The following is a description of a gene set: species: Mus musculus Genes predicted to be targets of miRBase v22 microRNA mmu_miR_8095 in miRDB v6.0 with MirTarget v4 prediction scores > 80 (high confidence targets). Mouse Gene Set: MIR_8095 from publication Chen Y, Wang X (PMID 31504780), and this is the list of marker genes: Far1, Slc5a1, Rnls, Kpna1, Pcdh15, Gart, Tnfsf13b, Mageb4, Sco1, Lcorl, Ms4a18, Golm1, Ptgdr, Miga1, Gm15091, Gm10439, Gm15107, E2f8, Cops2 (NCBI Gene Id 98909), Derl2, Slitrk4, Scfd1, Chd6, Sgo1, Fgf14, Stk33, Prkg2, Luc7l2, Tmem161b, Gpr33 (G protein-coupled receptor 33), Sgtb, Fbxo33, Spdye4a, Arid4b (NCBI Gene Id 94246), Hcrtr2, Nap1l3, Amfr, Pla2g2c, Rps6ka2, Tpgs2, Col26a1, Tkt, Pithd1 (NCBI Gene Id 99969), Usp50, Arfip1, Gm15097, Klhl31, Tmx4, Tecpr2, Gm15093, Mroh9, Adamtsl3, Ott, Smarca5, Luzp4, Acbd5, Gmps, Mapk1, Map4k5, Zfp111, Thap1, Gm15114, Hadh, Smg1 (NCBI Gene Id 72492), Cntn3, Rab39b, Klhl4, Vsig1, Gm15127, Zfp654, Ctdspl2, Fut4, Mylk, Rbm17, Cfap36, Leprotl1, Nap1l1, Arhgap12, Zcchc3, Spata6l, Pum2, Gria4, Gm15080, Scg3, Lrrc58, Gm15085, Med13, Patj, Samd4